Given this list of marker genes Adcy6, Adcy5, Slc5a5, Cftr, Gnai1, Efna5, Adcy2, Hrh3, Hnrnpk, Ptger3, Hdac8, Fdx1, Epha5 (NCBI Gene Id 13839), Adcy3, Adcy1, Adcy8, Creb1, Ahr, Akr1c18, here is a description of the gene set: Any process that results in a change in state or activity of a cell or an organism (in terms of movement, secretion, enzyme production, gene expression, etc.) as a result of a forskolin stimulus. species: Mus musculus Mouse Gene Set: GOBP_RESPONSE_TO_FORSKOLIN